Given this list of marker genes RPS11, RNF144B, ABHD3, RPL7, RPS9, CCNI, PIK3C2B, PPIA, PALM, FLOT2, METTL21A, SPR, RPS19BP1, ANXA3, PLEKHO2, PPP1R15A, RPL30, RHOJ, ARPC1B, GNG5, LRP11, BCL10, NDUFC1, RPL4, RPS16, SOD2, RPL12, LIMK2, MECOM, KTN1, NOL4L, EIF3K, CSNK1A1, ANAPC16, RNF122, RPL18, MANSC1, PKN3, SPNS2, MRPL33, RPS26, RPL23, EIF4EBP1, SEMA3A, RPL19, ADIRF, EEF1A1, FNIP2, FGD5, ASAP1, RPL7A, ATP5ME, RPL23A, BTNL9, RPS20, PALD1 (phosphatase domain containing paladin 1), RPL13A, CX3CL1, RBM8A, SDCBP (NCBI Gene Id 6386), NRARP, PPIB, MGST3, ACSL5, RPIA, CNTNAP3B, TCF4 (NCBI Gene Id 6925), GFOD1, SH3BGRL3, U2AF1, TRAPPC2B, BAG3 (BAG cochaperone 3), PDIA6, F11R, H3-3A, SP110, RPS3A, TMEM179B, LHX6, TMOD3, PROCR, ARPC2, FOXP1, PSMB8-AS1 (NCBI Gene Id 100507689), SIGIRR, BNIP2, OAZ2, FKBP1C, BZW2, GALNT18, SPG21, GNS, SHROOM1, SLC25A37, NUDC, FUS, ACTG1, CALR, CANX, BCL6B, CYP26B1, COX16, FGFR1OP2, KLHL2, CHMP4A, PITPNB, CA4, FAU, TMEM255B, DNAJB1, SELENOK, HID1, ADAM10, CFL1, SMAD6, SARS1, SOS1, RPL22, KRTCAP2, NNMT, UBA6, RPL24, RPS12, SMAGP, EEF1D, NACA, ABCD4, H2AZ1, PPFIA3, LSM4, STARD3, PTPN1, SNRK, PFN1, CLU, SASH1, BEX5, ARHGAP19, SUMO1, RPS10, HYAL1, here is a description of the gene set: Human Gene Set: GAUTAM_EYE_CHOROID_SCLERA_CHOROID_ENDOTHELIAL_CELLS Occular cell types curated from Gautam and Hamashima et al. Multi-species single-cell transcriptomic analysis of ocular compartment regulons from publication Gautam P, Hamashima K, Chen Y, Zeng Y, Makovoz B, Parikh BH, Lee HY, Lau KA, Su X, Wong RCB, Chan WK, Li H, Blenkinsop TA, Loh YH (PMID 34584087) species: Homo sapiens